The following is a description of a gene set: Genes up-regulated in CD8 T cells treated by interferon alpha: naïve versus day 8 after LCMV infection. Type 1 IFNs can conditionally activate all of the signal transducers and activators of transcription molecules (STATs), including STAT4. The best-characterized signaling pathways use STAT1, however, and type 1 IFN inhibition of cell proliferation is STAT1 dependent. We report that type 1 IFNs can basally stimulate STAT1- and STAT4- dependent effects in CD8 T cells, but that CD8 T cells responding to infections of mice with lymphocytic choriomenigitis virus have elevated STAT4 and lower STAT1 expression with significant consequences for modifying the effects of type 1 IFN exposure. The phenotype was associated with preferential type 1 IFN activation of STAT4 as compared to STAT1. Stimulation through the TCR induced elevated STAT4 expression, and STAT4 was required for peak expansion of antigen-specific CD8 T cells, low STAT1 levels, and resistance to type 1 IFN-mediated inhibition of proliferation. Thus, a mechanism is discovered for regulating the consequences of type 1 IFN exposure in CD8 T cells, with STAT4 acting as a key molecule in driving optimal antigen-specific responses and overcoming STAT1-dependent inhibition of proliferation. species: Homo sapiens Human Gene Set: GSE40666_NAIVE_VS_EFFECTOR_CD8_TCELL_WITH_IFNA_STIM_90MIN_UP from publication Gil MP, Ploquin MJ, Watford WT, Lee SH, Kim K, Wang X, Kanno Y, O'Shea JJ, Biron CA (PMID 22968462), and this is the list of marker genes: ZNF764, POLR1D, PNPLA7, SMPD5, THRA, SCAMP3, S100A6, GPR183, PITPNC1, TAMALIN, TAPBPL, KLRD1, TTC32, TMX4, TNFRSF25, RILPL2, ATP6V1E1, DAZAP2, LYPD6B, PCTP, CNN2, RHOC, CAPG, IGFLR1, DHRS13, PCDH9, CRLF3, DAAM1, PHC3, NKG7, PELI1, ANTXR2, SOCS3, DDRGK1, THY1, MYL2, EVI2B, TRIB2, RIPK2, FANCL, SLC16A8, TBX21, PCSK1N, ATP8B3, ASRGL1, MS4A6A, BTBD19, SCPEP1, PDCD10, ARRB1, COTL1, SGMS1, THADA, PDE5A, LPCAT2, GMPPA, LIMD1, GPR18, PRDM1, MYO10, DPY19L1, EEF1E1, PNPLA2 (NCBI Gene Id 57104), C3orf38, RBP3, RTN4R, F2RL2, GLIPR2 (GLI pathogenesis related 2), TNFAIP8L2, SOSTDC1 (sclerostin domain containing 1), EBAG9, TNFSF14, RAB33B, TOR4A, HLA-DQA1, CRIP1, GPR34, SIDT1, AHNAK, PCDHB2, LRRIQ4, FBXL4, NLN (neurolysin), MRM1, ANO10, FOXN2, CAPZA2, LATS2, PSME1, HLA-DRA, CRIM1, LIPT1, CD38, CNP, TRIM15, SIKE1, PLAAT3, B3GALT4, RPL6, PSMB9, CCDC169, SELPLG, GABRR2, IRGM, P2RX7, RAPGEF4, RAB7A, MACIR, HSD11B1 (hydroxysteroid 11-beta dehydrogenase 1), GNPTG, PDCD4, HSD17B7, WFIKKN2, EMP3, FBXO8, PLEKHA3, ADRB2, CRTC3, NIBAN1, SUSD3, CPNE4, SNX10, CCDC106, NOD1, AP3M2, DNAH8, SLC16A5, GNA15, GMFG, IFITM10, CDC14B, CD9 (NCBI Gene Id 928), MACROD1, LLGL2, PTS, TEX48, SESN1, FZD5, F2R, RFLNB, VANGL1, ATL3, CCNB1IP1, CXCR6, MYO6, PRMT3, PPM1K, IRF5, ENDOG, ZNF124, GPD1L, PIP4P2, RBM7, SERINC3, RIPPLY3, NSUN7, F2RL3, APP, APEH, SMIM5, SMG1, PDE1A, TRMO, FBXO22, ACBD4 (acyl-CoA binding domain containing 4, NCBI Gene Id 79777), NFIC, UBE2F (ubiquitin conjugating enzyme E2 F (putative)), ESRRA, NSMAF, ESYT2, NACC2, MYL12B, GM2A, KLK9, PCED1B, GCLC, PDE2A, EPSTI1, RAP2B, NUDT18, C16orf54, ABHD15, STK38, HYAL3, FLI1, ITGB7, FSCN1, TIAM2, ITGA7, NKIRAS2, KCNH3, FECH, RAB21, CEBPZOS, PPM1L, ARHGAP26, STARD7, TOM1, MFSD14A, FASLG